Given this list of marker genes Fgfr1, Cyp24a1, Cyp2r1, Enpp1, Fgfr4, Cyp27b1, Cyp27a1, here is a description of the gene set: The chemical reactions and pathways involving vitamin D3, (3S,5Z,7E)-9,10-secocholesta-5,7,10(19)-trien-3-ol. Mouse Gene Set: GOBP_VITAMIN_D3_METABOLIC_PROCESS species: Mus musculus